The following is a description of a gene set: Any process that results in a change in state or activity of a cell or an organism (in terms of movement, secretion, enzyme production, gene expression, etc.) as a result of a cGMP (cyclic GMP, guanosine 3',5'-cyclophosphate) stimulus. studied in species Mus musculus Mouse Gene Set: GOBP_RESPONSE_TO_CGMP, and this is the list of marker genes: Npr2, Hcn4 (hyperpolarization-activated, cyclic nucleotide-gated K+ 4), Ren1, Pde2a, Slc6a4, Tlr7, Hcn2, Rapgef2, Pde3a